The following is a description of a gene set: Human Gene Set: GSE42088_2H_VS_24H_LEISHMANIA_INF_DC_UP Genes up-regulated in dendritic cells infected by Leishmania major: 2h versus 24h. from publication Favila MA, Geraci NS, Zeng E, Harker B, Condon D, Cotton RN, Jayakumar A, Tripathi V, McDowell MA (PMID 24808365) species: Homo sapiens Leishmania major infected human dendritic cells (DCs) exhibit a marked induction of IL-12 ultimately promoting a robust Th1-mediated response associated with parasite killing and protective immunity. In this study, we utilized Affymetrix Genechips to globally assess the host cell genes and pathways associated with L. major infection during early infection (2, 4, 8, and 24 hrs) in human myeloid-derived DCs. Bioinformatic analyses of the hybridized microarray chips identified genes, represented by 848 unique probe sets, which, when compared to uninfected samples were observed to be significantly differentially expressed by one-way ANOVA. Altogether, the data provide a genome-wide perspective on the transcriptional influences Leishmania species exert within human DCs during early infection, and provides a platform for further investigations toward functionally characterizing candidate genes of importance to the IL-12 based immune response to infections. In the current study, we further investigate the L. major infected DC transcriptional during early time points after infection via microarray analysis., and this is the list of marker genes: SIGIRR (single Ig and TIR domain containing), RAP2B, EIF3L, CD52, ICAM3, CST3, SH3TC1, CNPY3, IFITM3, NLRP1, RPS29, ADD3, RPS9, EPRS1, ZFP36L1, RNF130, GPX1, TSPO, PPT1, MINK1, TKT, CAST, TLE5, KLF4 (NCBI Gene Id 9314), FCGRT, ATP5MC2 (NCBI Gene Id 517), SCP2, SLC8B1, OXA1L, ITGB2, ARRB2, SH3BGRL, CHP1, PYCARD, CYTH4, ARL4C, INPP5K, SECTM1, AMPD2, MCUB, CCDC69, ITGAM, CD37, ALOX5, HLA-DMB, PLP2, CDA, CRISPLD2, RPS15A, MKNK2, GSTK1, SLC41A3, CSF3R, ZCCHC24, PIGT, MZT2B, SLC9A1, EIF2D, PCBP2, TGFBI, PLBD1, LSP1 (NCBI Gene Id 4046), MXI1, LTA4H, LAPTM5, PHYH, SMARCD3, TACC3, HIGD2A, PLD3, EIF3F, RPL27, YPEL5, EBP, HEXA, MAPRE2, FBP1, PPM1F, LGALS9, HLA-DPB1, TOR3A, PRCP, SFN, HMGB2, ARHGDIB, ERGIC3, EIF3E, RPL21 (NCBI Gene Id 6144), TSC22D3, MID1IP1, LYZ, CLMN, RAB11FIP1, CMC4, PECAM1, PTMA, PIGL, CCPG1, RGS2, RPL31, BBLN, CRTAP, KIAA0513 (KIAA0513), MS4A4A, LRRFIP1, FCN1, JUND, APOBEC3A, ZFP36, RASSF2, PIGB, GPI, ALDOC, CD4, COTL1 (coactosin like F-actin binding protein 1), NR4A1, HMOX1, MYD88, NACA4P, IFNGR1, MNT, NDUFB11, SASH3, ASAH1, GUSB, CD86, EID1, REEP4, RACK1, TESC, ARHGAP4, BST1, FOS, ZFAND1, TIMP2, RPL41, SCPEP1, RPL36A, LY86, CD302, THEMIS2, EVI2A, IFITM2, MPPE1, MAN2A2, CELF2, CD14, POLB, REX1BD, CTSS, TECR, CARS2, NOD2, NR4A2, MTMR3, RNASET2, GPR65, MNDA, TMX4, DPEP2, KLF2, CRBN, KCNAB2 (NCBI Gene Id 8514), OAT, SELPLG, CUTA, RIN3, VPS51, TMEM8B, S100A4, EVI2B, ERP29, CNN2, LST1, MPC1, LY6E, RPS28, HSPBAP1, GDPD5, HSD17B11, C5AR1, ITM2B, ALDH2, H1-10, CTSD, PXN, PDK3 (NCBI Gene Id 5165), SLC25A6, KCNQ1, TACC1, LBR, RPS13, ENSA, ACOX2, SARAF, MPP1, RNASE6, PTK2B, SNHG32, CCNB1IP1